The following is a description of a gene set: The region of the plasma membrane that includes the basal end and sides of the cell. Often used in reference to animal polarized epithelial membranes, where the basal membrane is the part attached to the extracellular matrix, or in plant cells, where the basal membrane is defined with respect to the zygotic axis. Human Gene Set: GOCC_BASOLATERAL_PLASMA_MEMBRANE species: Homo sapiens, and this is the list of marker genes: CDH17 (NCBI Gene Id 1015), SLCO4C1, CASK, CTNNA2 (catenin alpha 2), TRPC4, ANXA1, ANK1, SLC6A9, SLCO1B7, AP2A1, SLC4A9, CNNM2, TLR9, SLC12A2, SLC38A1 (NCBI Gene Id 81539, solute carrier family 38 member 1), SLC26A11, BEST1, SLC4A8, OTOF, CA11 (carbonic anhydrase 11), ATP1A1, ATP7B, C5AR1, NUMB, ABCC4, ERBB3 (erb-b2 receptor tyrosine kinase 3), FRMPD2, FLOT2, ERBB2, MTTP, SLC12A6, ATP6V0A4, DAG1, PTH1R, ANXA2, LRP1, AQP7B (aquaporin 7B), ATP2C2, AQP9, CLCNKB, ABCC6, ST14, ABCB11, EPPK1, SLC4A10, DSP, SLC22A7, SLC14A1, KCNJ16 (NCBI Gene Id 3773), LIN7B (NCBI Gene Id 64130), AURKA, PROM2, CA12, SPEF1, ITGA3, LIN7C, STX2, SLC26A5, PDGFB, SLC41A1, KCNQ1, AQP7, CXADR, MAP7, SLC8A2, SLC22A3, ANK2, CLCN2, SLC6A13, SLC2A9, CHRM3, FLOT1, SLC4A11, SLCO2B1, AQP1, ABCC5, SLC16A8, FOLR1, SLCO3A1, TFRC, VANGL2, SCRIB, HSP90AA1, AJAP1, SLC51A (solute carrier family 51 member A), CALHM1, SLCO1B3-SLCO1B7, CAV1, CD81, SLC19A1, CLDN19, TSHR, ABCC10, STK39, ABCA8, SLC30A1, DLG1, CA9, CDH2, EGFR, SLC22A6 (NCBI Gene Id 9356), SLC16A1, DLG2, SLC47A1, IDE, NDRG4, SLC26A7, SLC16A3, ANXA13 (NCBI Gene Id 312), EPB41, EZR, SLC16A10, CADM1, SLC26A1, ATP7A, SLC4A2, RHBG, RAB17, CA4 (carbonic anhydrase 4), SLC9A1, SLCO1A2, HEPH, SLC16A6, EPCAM, FXYD2, AQP2, SLC22A9, LDLR, SLC43A2, SLC17A5, PKD1, SLCO5A1, NAIP, SLC51B, SLC9B2, SLC6A12, DIO1, CLDN17, SLC43A3, CDH16, CD300LG, ATP2B4, DSTYK, PDPN, KCNJ10, SLC3A2, SLC7A5, SLC5A3, VSIG1, CLDN7, MSN, SLC22A8, KCNJ4, PKD2, SLC7A1 (solute carrier family 7 member 1), DLG3, SLCO1B1, BSG, ABCA1, AQP4, PLPP3, CLDN8, SLC5A6, SLC16A5, AQP8, LPO, SLC40A1, SLC46A1, NKD2, NEDD9 (neural precursor cell expressed, developmentally down-regulated 9), UMOD, ADCY8, AQP3, ALPK2 (alpha kinase 2), FXYD4, MYO1D, MARVELD2, SLC4A4, TGFBR3 (NCBI Gene Id 7049), ABCC1, S100G, SLC39A8, SLC4A7, SLC22A2, SLC23A2, STXBP3, PDZD11, SLC39A14, ANK3, LIN7A, CD44, SLC16A7, CLDN1, CD1D, SLC9A4, CA14, CALHM3, SLCO1B3, LRRC7, GPIHBP1, KCNC2, SLC7A7, NOD2, BSND, SLC29A4, ATP2B1, SLC22A1, ATP6V1B1, BEST2, RHCG, SLC29A1, SLC31A1, IQGAP1, SLC29A2, ERBB4, MEGF11 (multiple EGF like domains 11), SLCO6A1, SLCO2A1, CEACAM5, WASF2, AQP10, SLC13A3, ATP2B2, PIANP, SLC10A1, SLC6A6, SLC7A8, ATP1B3, STX4, SLCO1C1, ERBIN, ADRA2A, SLCO4A1, HPGD, TJP1, SLC4A1, LEPR (NCBI Gene Id 3953), CD38, CNNM4, FXYD5, CASR, GM2A, ENPP1, MUC20, SLC2A1, TGFA, P2RY1 (purinergic receptor P2Y1), TEK, PALM (paralemmin), MAP4K2, ORAI1, MYO1A, SLC16A12, CTNNB1, B4GALT1, SLC26A6, ATP1B1, SLC38A3, NOD1, SLC39A5, ADORA1, ATP12A, SLC4A5, MLC1, SCTR, CLCNKA (chloride voltage-gated channel Ka), ABCC3, HCN1